The following is a description of a gene set: Genes up-regulated in comparison of control RAW264.7 cells (macrophages) versus those infected with B. abortus. Identification of host responses at the gene transcription level provides a molecular profile of the events that occur following infection. Brucella abortus is a facultative intracellular pathogen of macrophages that induces chronic infection in humans and domestic animals. Using microarray technology, the response of macrophages 4 hours following B. abortus infection was analyzed to identify early intracellular infection events that occur in macrophages. Of the more than genes, we identified over genes that were reproducibly differentially transcribed. First, an increase in the transcription of a number of pro-inflammatory cytokines and chemokines, such as TNF-α, IL-1β, IL-1α, and members of the SCY family of proteins, was evident that may constitute a general host recruitment of antibacterial defenses. Alternatively, Brucella may subvert newly arriving macrophages for additional intracellular infection. Second, transcription of receptors and cytokines associated with antigen presentation, e.g., MHC class II and IL-12p40, were not evident at this 4 hour period of infection. Third, Brucella inhibited transcription of various host genes involved in apoptosis, cell cycling, and intracellular vesicular trafficking. Identification of macrophage genes whose transcription was inhibited suggests that Brucella utilizes specific mechanisms to target certain cell pathways. In conclusion, these data suggest that B. abortus can alter macrophage pathways to recruit additional macrophages for future infection while simultaneously inhibiting apoptosis and innate immune mechanisms within the macrophage permitting intracellular survival of the bacterium. These results provide insights into the pathogenic strategies used by Brucella to survive long-term within a hostile environment. Human Gene Set: GSE8384_CTRL_VS_B_ABORTUS_4H_MAC_CELL_LINE_UP from publication Eskra L, Mathison A, Splitter G (PMID 12595423) species: Homo sapiens, and this is the list of marker genes: TERF1, PHKA1, ARHGAP45, RAB3D, CRBN, DYNLT3, ITGA6 (integrin subunit alpha 6), MGST3, ANTKMT, CKMT2, POU2F1, CCNG2, NCBP2AS2, NFIC, RERE, POLD4, COMT, RPP30, MARVELD1, NCOA6, PDCD4, MYO9A, DOLPP1, ABCD1, MME, COQ10A, PAX6, DCT, MMS19, ZNF362, CHMP6, WDHD1 (WD repeat and HMG-box DNA binding protein 1), H3C7, KITLG, ST6GALNAC4, PTTG1, MEF2C, HOXC8, COA3, CHEK2, CDV3, CRAMP1, SFMBT2, SERF1A, PAQR7, AAMDC (NCBI Gene Id 79737), TK1, NEDD1, TBL3, OTULINL, RASA3, SUB1, TMEM141, RNASE4, EFHD1, H1-0, S100A6 (NCBI Gene Id 6277), PBX2, ANGPT2, PIK3C3, REV3L, IL6R, RGS2, MELK, VAPB, NCOA3, MNT, NUSAP1, PARD6A, RPL37 (ribosomal protein L37), GAMT, CD99, SLA, AK1, PDE7A, TSN, NFIX, CDKN3, ETFBKMT, MLLT3, GTPBP2, ACOX1, ARL2, MED14 (NCBI Gene Id 9282), SMIM14, ATP2A3, TBC1D24, RAB11FIP5, RNF167 (ring finger protein 167), ING4, LMO4, PCYOX1, SDHAF1, SELENOH, TMEM205, HELB, PRKCH, TNFAIP8L1, KCNS2, MRTFA, DCPS, CRYBG1, PSENEN, PDK1, COL2A1, PTPN21, YBX1, HDAC5, PHLDA3, SIN3A, COL15A1, SCD, SOX11, PARG, MAP3K1, MCEE, CXCR4 (C-X-C motif chemokine receptor 4), SESN1, HOXB7, RAD1, FKBP2, TNFRSF17, PTAFR, WEE1, HAUS4, PCDHA13, SH3BP1, IL7, MBD4, TSEN34, CST7, CREBRF, TSPO, CBX3, ST8SIA4, PIK3R2, PLEKHA5, UVRAG, IDNK, ADCY9, UBALD2, CYTIP, ZFTRAF1, VPS13C, RNASEH2C (NCBI Gene Id 84153), MTMR10, ALG3, TPRA1, DAZAP1, MLST8, AP1B1, SBF2, CNTROB, CIC, LPIN1, PTMS, PKIB, RBL2, ATOX1, NCOA1, IFT81, GNPDA1, MIF4GD, CHAF1A, ESYT1, PHKA2, FLI1, IRF1, EBF3, SKA2, RNF26, TMT1A, GOLGA7, CBX2, ASB3, EDNRB, PEX14, MLLT10, ARRB1, EZH1, MYH2, TANGO2, STARD3, FGF6, PKNOX1, MYOM1, PLEKHO1, PTPN18, ZDHHC14 (NCBI Gene Id 79683), NRP1, RCAN3, PTPRO, PEF1, CENPK, NAXE, PCK2, STX2, MTMR1, FOXO3